Given this list of marker genes TNFRSF21, FCGR2B, TBC1D10C (NCBI Gene Id 374403), BANK1, CTLA4, NDFIP1, ATM, PKN1, ID2, INHBA, INHA, LYN, PARP3 (NCBI Gene Id 25908), BTK, HMGB3, CR1, SFRP1, FOXJ1, LAPTM5, TNFAIP3, CDKN2A, INPP5D, CASP3, SAMSN1 (NCBI Gene Id 64092), MNDA, PAWR, BCL6, CD300A, MIR185, TYROBP, RC3H1, IL10, TNFRSF13B, FOXP3, here is a description of the gene set: Human Gene Set: GOBP_NEGATIVE_REGULATION_OF_B_CELL_ACTIVATION Any process that stops, prevents, or reduces the frequency, rate or extent of B cell activation. species: Homo sapiens